Given this list of marker genes KRT1, SMARCAD1, KDF1 (keratinocyte differentiation factor 1), GJB2, KRT16, AQP5, KRT9, LORICRIN, CAST, here is a description of the gene set: Knuckle pads are benign fibrofatty subcutaneous pads located over the proximal interphalangeal (PIP) joints that can be mistaken for arthritis. Rarely they affect the dorsal aspect of the metacarpophalangeal (MCP) joints. Clinically they are painless and often affect both hands in an asymmetrical pattern. Knuckle pad studied in species Homo sapiens Human Gene Set: HP_KNUCKLE_PAD